The following is a description of a gene set: species: Homo sapiens Aplasia or developmental hypoplasia of the ovary. Human Gene Set: HP_APLASIA_HYPOPLASIA_OF_THE_OVARY Aplasia/Hypoplasia of the ovary, and this is the list of marker genes: KISS1R, BBS1, IFT27, ZFPM2, VAMP7, ARL6, BBS7, PROKR2, BBS4, SPRY4, TACR3, NSMF, SPIDR, NHLH2, SDCCAG8, ALG9, PSMC3IP, DUSP6 (dual specificity phosphatase 6), GNRH1, TTC8, MRPS22, LETM1, WWOX, LEP (NCBI Gene Id 3952), LARS2, NPHP1, NR5A1, HROB, WDPCP, MKKS, PIGG, BBIP1, KISS1, SCAPER, FOXL2 (forkhead box L2), NR0B1, IFT172, SETBP1, CPLX1, CLPP, DHH, PROK2, GNRHR (gonadotropin releasing hormone receptor), PPP1R12A, WT1, FIGLA, MSH4, HFM1 (helicase for meiosis 1), ZSWIM7 (NCBI Gene Id 125150), HS6ST1, FGF17, LZTFL1, GATA4, SRY, SCLT1, CHD7, BBS5, HARS2, NDNF, NELFA (negative elongation factor complex member A), CEP19, PTPN11, CEP290, NSD2, NOBOX, BBS2, C14orf39, CFAP418, SOX9, BNC1, PMM2, CTBP1, ZPR1, BMP15, MAP3K1, POLR3H, BBS10, FGFR1, ERAL1, MCM8, FGF8, DHX37, MKS1, TP63, BBS12, BBS9, FSHR, WDR11, STAG3, AR, LEPR, IFT74, TRIM32, TAC3, PAX6, NUP107